Given this list of marker genes CUBN, BBS1, SOWAHA, GIMAP8, NDNF, DDX18, ARHGAP28, FRAT2, ARHGEF19 (NCBI Gene Id 128272), EIF3K, GNG12, DHX58, MCUB, FAP, DMTN, MPV17L, CITED4, DNAJC28, BCS1L, DOHH, CD40LG, ALOX12, CHKA, COX7A1 (NCBI Gene Id 1346), DNAH12, CCS, CCDC115, SAXO4, GABRR3, AAMP, C2orf15, CNNM4, CFAP298, CREB3L4, SCN8A, DOC2A, TMEM263, ECM1, ECI2, ASB12, CETN2, DOCK2, ECM2, GPC3, FBXL14, OGFOD3, CHRNG, DLD, CGGBP1, LINC03040, ADAMTSL3, ARPIN, C17orf75, EEF1D, FAM47A, C3orf85, SMG8, ANKRD52, FHL1, ALDH16A1, CCDC88C, LINC01550, COIL, ADAMTS5, TRAPPC11, ARIH1, CA8, CCDC15, DDX11L2, AFAP1, THEMIS2, EPHX3, AKAP9, DMBX1, APOL6, DNAJB14, MVB12B, CD46, COBL, CALCA, ALK, BBOX1, CHRNB2, LINC02210, BCDIN3D, BID, DLX1, SLC25A3P1, FGF13, DUSP14, BMS1P1, ASB8, ANAPC7, CNPY1, C11orf21, DNTTIP1, CDH15, EIF2AK3, FAM111B (FAM111 trypsin like peptidase B), BCOR (NCBI Gene Id 57686), BAALC-AS2, ALDH6A1, FAIM, FUS, ETV6, TMEM8B, CCDC28B, CSPG5, SUCO, EFCAB10, C1QTNF7, CXCL14, ACTR3B, CD3E, BLCAP, FITM1, AKR1A1, CRBN, DDAH2, ZGRF1, CTAG2, CLTCL1, GPC2, ERP29, C3orf70, ANO8, FOSL2-AS1, BCL11A, LINC00951, INTS6L, FOXRED2, CCNY, CHRNA1, CHCHD7, CTTNBP2, FBXO46, CDHR5, G3BP2, CACNG7 (calcium voltage-gated channel auxiliary subunit gamma 7), CSNK2B, CABLES1, CSH1, CCDC180, CDS1, CARD19, DYNC1I1, COL10A1, FBXW9, EVX1, CAMK1D, BPIFB6 (NCBI Gene Id 128859), C8orf17, C2CD2, EML1, DEPTOR, GGA2, ADAMTSL1, GATC, CCL4, COG1, FAM86C1P, SIGLECL1, FAM21EP, C1R, GMNC, GCAT, CPNE3, CYMP, CUTA, BOLA1, AGRN, DAD1, GABARAPL3 (GABA type A receptor associated protein like 3 (pseudogene)), CXCL2, ENPP7, ANAPC15, BOLA3, TMA7, ETNK2 (NCBI Gene Id 55224), LINC02880, PAGR1, ATXN1L, ZBTB7C-AS2 (NCBI Gene Id 84322), ASF1A, FCSK, DDT, CABP2 (NCBI Gene Id 53597), AP4B1, CD7, AK9, CCDC152, BTAF1, C12orf60, MFSD12, CDC26, ATP13A5, here is a description of the gene set: from publication Miyara M, Yoshioka Y, Kitoh A, Shima T, Wing K, Niwa A, Parizot C, Taflin C, Heike T, Valeyre D, Mathian A, Nakahata T, Yamaguchi T, Nomura T, Ono M, Amoura Z, Gorochov G, Sakaguchi S (PMID 19464196) Gene expression profiles of subsets of CD4+ T cells according to their expression of FoxP3 and CD45RA were compared. FoxP3 is a key transcription factor for the development and function of natural CD4+ regulatory T cells (Tregs). Here we show that human FoxP3+CD4+ T cells are composed of three phenotypically and functionally distinct subpopulations: CD45RA+FoxP3low resting Tregs (rTregs) and CD45RA-FoxP3high activated Tregs (aTregs), both of which are suppressive in vitro, and cytokine-secreting CD45RA-FoxP3low non-suppressive T cells. The proportion of the three subpopulations characteristically altered in cord blood, aged individuals, and patients with immunological diseases. Terminally differentiated aTregs rapidly die while rTregs proliferate and convert into aTregs in vitro and in vivo as shown by the transfer of rTregs into NOD-scid-common gamma-chain-knockout mice and by TCR sequence-based T cell clonotype tracing in peripheral blood of normal individuals. Taken together, the dissection of FoxP3+ cells into subsets enables one to analyze Treg differentiation dynamics and interactions in normal and disease states, and to control immune responses through manipulating particular FoxP3+ subpopulations. Genes up-regulated in comparison of naive CD4 T cells versus non-suppressive T cells. species: Homo sapiens Human Gene Set: GSE15659_NAIVE_CD4_TCELL_VS_NONSUPPRESSIVE_TCELL_UP